The following is a description of a gene set: Mouse Gene Set: GOCC_CYTOCHROME_COMPLEX A protein complex in which at least one of the proteins is a cytochrome, i.e. a heme-containing protein involved in catalysis of redox reactions. studied in species Mus musculus, and this is the list of marker genes: AA467197, Cox7a1, Cox5a, Uqcrc1, Uqcrc2, Cox8a, Cox7c (cytochrome c oxidase subunit 7C, NCBI Gene Id 12867), Cox7a2l, Cox6b2, Uqcr11, Uqcrh, Cox6c2, Uqcrh-ps1, Ndufa4, Ugt1a1, mt-Co2, mt-Co3, Cox7b (NCBI Gene Id 96903), Uqcrb, Cox10, Cox6a2, Cox4i2, Cyc1, Cox6a1, Cox8c, mt-Co1, Cox5b, Cox7b2, Cox6b1, Cox15, Uqcc3, Uqcrfs1, Cox6c, Cox7a2, Uqcr10, Uqcrq, Cox8b (NCBI Gene Id 12869), Ndufa4l2, Cox4i1, mt-Cytb